The following is a description of a gene set: Catalysis of the reduction of a ketone group to form the corresponding alcohol. Mouse Gene Set: GOMF_KETOREDUCTASE_ACTIVITY studied in species Mus musculus, and this is the list of marker genes: Akr1c20, Akr1c6, Akr1c18, Akr1c14, Akr1cl